Given this list of marker genes SMAD9, TIMM50, AKAP12, EZH2, TNNT2, B3GAT2, FAM43B, SERINC2, SIX3, POP5, CLINT1, FPGS, CRABP1, OTUB2, CA2, PTCD2, SYTL2, COL26A1, BCL7A, ZMYND19, LRIG1, YBX1, BCKDHA, EPHX2, MOGS, TPTE, SYT5, AMOTL1, RFC3 (replication factor C subunit 3), EPS8L2, RHPN2, HIRIP3, MGAT4A, ADCY8, PTK2, RBM19, UCP2, POLR3G, CA3, SH3TC1, MAOA, SHC4 (SHC adaptor protein 4), COL4A2, TMEM144, HDAC4, LYAR, RPS19BP1, DDX31, RUVBL1, COMTD1, PA2G4, MEMO1, ZAN, MYL3 (NCBI Gene Id 4634), MCM6, TMEM41A, POLD1, CCDC81, ZFPM1, FAM185A, AIMP2, TERB2, ARVCF, CARNMT1, SNRNP35, GPD1L, RRAS2 (RAS related 2), CFDP1, OR51B4, TIMM8A, CYB5A, CFAP57, FGF5, ZBBX, CHCHD6, KLC3 (kinesin light chain 3), SOX15, GZMA, MTAP, LGMN, ADISSP, MRPS17, BCAT1, EIF2S2, FXN, MCM7, ACP6, GSE1, CACYBP, SCN4B, FAM53B, ZNRD2, CCDC107, TTC4, PSMB3, ADGRV1, NAF1, DRC12, PARP1, RAE1, CRACDL, SCGN, KRBA1, GSG1, PLXNA1, SH3TC2, DCTPP1, HTR2B, HAUS1, AATF, CLIP2, VPREB3, GAS2 (growth arrest specific 2), RILPL1, SCN2B, DLGAP5, SLC19A2, GTSE1, LEFTY2, EFHB, GINS1 (NCBI Gene Id 9837), RSPH9, RET, GFRA2, CNDP2, SNAP91, CCT3, PRKAA2, ELL3, MPZL1, ERCC1, CTPS1, TEX30, NASP, MEGF6, MARS1, CHCHD10, GPATCH2 (NCBI Gene Id 55105), CATSPERZ, JMJD4, PI4KA, NUPR2, GC, ADK, GPAA1 (NCBI Gene Id 8733), RARRES2, MRPL37 (NCBI Gene Id 51253), PKP4, PSMC3IP, KCNA5, HSPE1, CEP164, CMSS1, MAP4K2, GAR1, TRMT9B, CAPN3, MS4A1, SCRN3 (NCBI Gene Id 79634), GRP, ADGRA1, SPARCL1, PAXIP1, PACS2, SDAD1, RTN4RL2, CDCA5 (NCBI Gene Id 256676), STRBP, CHCHD3, ARHGAP21, SEPHS2, PDE2A, PMS2, LCT, ZDHHC14, ATP1A2, PRKCD, CSRP1, OTUD3, ZNHIT6, NEUROD4, CARM1, AQP6, ZDHHC13, SAPCD2, SLC5A7, AGFG1, ERCC8, MC1R, COA6, TIPIN, TMPRSS6, DENND2B, HIPK2, LONRF1, CCND3, NDE1 (NCBI Gene Id 95348), TRMT11, MMP13 (matrix metallopeptidase 13), MYBPHL (NCBI Gene Id 343263), here is a description of the gene set: Murine Cytomegalovirus (MCMV) infection leads to early activation of various immune cells, including B and T lymphocytes, before the actual initiation of antigen-specific adaptive immunity. This activation is partly driven by innate cytokines, including type I interferon (IFN), which are induced early after infection. The objective of this study was to address the role of type I IFN in shaping early/innate B and T cell responses to a primary acute viral infection. In order to decipher the specific impact of IFN-I on cell subsets, we performed a genome-wide expression analysis on WT splenic B and CD8 T lymphocytes isolated from C57BL/6 mixed bone marrow chimera mice. This study complements series GSE39555, which focused on early responses of NK cells and of the two subsets of conventional dendritic cells. studied in species Homo sapiens Genes up-regulated during primary acute viral infection: NK cells versus ITGAM+ dendritic cells. Human Gene Set: GSE45365_NK_CELL_VS_CD11B_DC_MCMV_INFECTION_UP